The following is a description of a gene set: Human Gene Set: GOBP_MESANGIAL_CELL_DIFFERENTIATION The process in which relatively unspecialized cells acquire specialized structural and/or functional features that characterize the mesangial cells of the kidney as it progresses from its formation to the mature state. studied in species Homo sapiens, and this is the list of marker genes: NOTCH1, CD34, PDGFB, ACTA2, GPR4, OSR1, FOXC2